The following is a description of a gene set: Proximal renal tubular acidosis studied in species Homo sapiens Human Gene Set: HP_PROXIMAL_RENAL_TUBULAR_ACIDOSIS A type of renal tubular acidosis characterized by a failure of the proximal tubular cells to reabsorb bicarbonate, leading to urinary bicarbonate wasting and subsequent acidemia., and this is the list of marker genes: EHHADH, GATM, CA2, SLC34A1, NDUFAF6, ALDOB, OCRL, PC (pyruvate carboxylase), SLC4A4, GATA3, UQCC2